Given this list of marker genes ACTA1, NF2, CADM3, REEP1, PLOD1, MORC2, LDB3, here is a description of the gene set: A condition in which the affected individual cannot extend the wrist, which hangs flaccidly. Wrist drop studied in species Homo sapiens Human Gene Set: HP_WRIST_DROP